Given this list of marker genes FOXP3, FOXN1, FAS, HMOX1, TNFRSF4, DOCK11 (dedicator of cytokinesis 11), SOCS1, CASP10, LAT, FASLG, here is a description of the gene set: Human Gene Set: HP_COOMBS_POSITIVE_HEMOLYTIC_ANEMIA A type of hemolytic anemia in which the Coombs test is positive. Coombs-positive hemolytic anemia species: Homo sapiens